Given this list of marker genes ITPKB, CD3E, TOX, CD74, PTPN2, SRF, DOCK2, FOXN1, SHH, CD3G, STK11, NFATC3, CD3D, PTPRC (protein tyrosine phosphatase receptor type C), ZAP70, here is a description of the gene set: Human Gene Set: GOBP_POSITIVE_THYMIC_T_CELL_SELECTION The process of sparing immature T cells in the thymus which react with self-MHC protein complexes with low affinity levels from apoptotic death. studied in species Homo sapiens